Given this list of marker genes Hes5, Nudt21, Hes1, Ankle1, Znhit1, Zbtb1, Fnip1 (NCBI Gene Id 216742), Sos1, Pcid2 (PCI domain containing 2), Notch1, Flcn (folliculin), Sos2, here is a description of the gene set: studied in species Mus musculus Any process that modulates the frequency, rate or extent of lymphoid progenitor cell differentiation. Mouse Gene Set: GOBP_REGULATION_OF_LYMPHOID_PROGENITOR_CELL_DIFFERENTIATION